The following is a description of a gene set: Any process that modulates the frequency, rate or extent of a respiratory system process, an organ system process carried out by any of the organs or tissues of the respiratory system. Human Gene Set: GOBP_REGULATION_OF_RESPIRATORY_SYSTEM_PROCESS studied in species Homo sapiens, and this is the list of marker genes: ATP1A2, FTO, NLGN3, MECP2, MTG2, GLS, GLRA1, PHOX2B, GSX2, MTG1, PBX3, TLX3, ADORA1 (NCBI Gene Id 134), NLGN2, TSHZ3, CC2D1A